Given this list of marker genes Mapk8, Arhgef17, Arhgef38, Arhgef3 (Rho guanine nucleotide exchange factor 3), Fgd1, Ikbkb, Rela, Arhgef7, Psen1, Ngfr, Nfkb1 (NCBI Gene Id 18033), Bad, Mag, Myd88, Arhgef10l, Fgd2, Arhgef10, Ngef, Vav1, Rps27a, Ywhae, Arhgef12, Casp2, Arhgef1, Irak1, Ngf, Sqstm1, Prex1, Gna13, Casp3 (caspase 3), Itgb3bp, Omg, Arhgef37, Arhgef39, Nfkbia, Lingo1, Arhgef15, Ubb, Rtn4, Itsn1, Psenen, Arhgef33, Sos2 (NCBI Gene Id 20663), here is a description of the gene set: studied in species Mus musculus electronically inferred by orthology from the curated human pathway This event has been computationally inferred from an event that has been demonstrated in another species.<p>The inference is based on the homology mapping from PANTHER. Briefly, reactions for which all involved PhysicalEntities (in input, output and catalyst) have a mapped orthologue/paralogue (for complexes at least 75% of components must have a mapping) are inferred to the other species. part of: Death Receptor Signaling Reactome Pathway: p75 NTR receptor-mediated signalling